Given this list of marker genes ERBB2, FZD4 (frizzled class receptor 4), FOS, KCNN4, STK11, PKD2, IKBKB, WNT9A, FLT1, PRKAB1, NRAS, PRKAB2, JUN, WNT1, PRKACG, FZD6, CCND1, WNT5B, CFTR (CF transmembrane conductance regulator), WNT10A, WNT7A, WNT8B, VEGFB, DVL2, RPS6KA1, KRAS, IGF1, WNT5A, SFRP4, PRKAG1, WNT3, KDR, CTNNB1, SRC, TNF, FZD10, FZD7, GSK3B, WNT6, SLC12A2, FZD5, BRAF, PLCG2, GNAI2, PRKAG2, FZD8, WNT7B, MTOR, MYC, PKD1, TSC1, WNT2B, GNAS, FZD2, PRKAG3, FZD1, WNT3A, WNT8A, WNT2, MAP2K2, PRKAA2, GNA11, IGF1R, AVPR2, TSC2, ADCY6, PRKAA1 (protein kinase AMP-activated catalytic subunit alpha 1), GNAQ, DVL1, WNT11, GNAI1, WNT16, RHEB, WNT10B, MAPK3, WNT4, WNT9B, FZD9, HRAS, EGF, GNAI3, FZD3, DVL3 (dishevelled segment polarity protein 3), SSTR2, PDE1A, here is a description of the gene set: Human Gene Set: WP_POLYCYSTIC_KIDNEY_DISEASE_PATHWAY species: Homo sapiens Polycystic kidney disease pathway